The following is a description of a gene set: Mouse Gene Set: chr2G1 studied in species Mus musculus, and this is the list of marker genes: Dstn, Gm11645, Gm14082, 4933406D12Rik (RIKEN cDNA 4933406D12 gene), Cfap61, Zfp133-ps, Ralgapa2, Gm14117, Rpl26-ps5, Pet117, Pcsk2os1, Scp2d1, Insm1, Banf2, Gm11686, Gm14083, Gm11700 (NCBI Gene Id 606731), 1700108N11Rik, Gm11764, Rbmx2-ps, Crnkl1, Gm14092, Gm14111, Pcsk2 (proprotein convertase subtilisin/kexin type 2), Gm11687, Snord17, Snx5, Fau-ps1 (NCBI Gene Id 14110), Kiz, Gm22310, 4930444E06Rik, Gm5535, Macrod2os1, Otor, A930019D19Rik, Sec23b, Kat14, Gm11759, Pcsk2os2, Rbbp9, Smim26, Dtd1, Snrpb2, Kif16b, Rrbp1, Naa20, Kif16bos, Mgme1, Rps13-ps6, Dzank1, Gm26165, Bfsp1, Gm11743, Polr3f, Rin2 (NCBI Gene Id 99432), Ovol2, Gm11701, Gm14114 (predicted gene 14114), Banf2os, Slc24a3